The following is a description of a gene set: from publication Amit I, Garber M, Chevrier N, Leite AP, Donner Y, Eisenhaure T, Guttman M, Grenier JK, Li W, Zuk O, Schubert LA, Birditt B, Shay T, Goren A, Zhang X, Smith Z, Deering R, McDonald RC, Cabili M, Bernstein BE, Rinn JL, Meissner A, Root DE, Hacohen N, Regev A (PMID 19729616) studied in species Homo sapiens Human Gene Set: GSE17721_LPS_VS_CPG_8H_BMDC_DN Genes down-regulated in comparison of dendritic cells (DC) stimulated with LPS (TLR4 agonist) at 8 h versus DC cells stimulated with CpG DNA (TLR9 agonist) at 8 h. mouse primary BMDCs were stimulated with tlr ligands and gene expression changes were profiled on Affymetrix arrays, and this is the list of marker genes: CETN3, STT3A, SLC35A1, GSDME, FKBP1A (FKBP prolyl isomerase 1A), PLA2G6, SS18L2, TMEM186, DCPS, SEPTIN8, NUP54, IMPACT, CPB1, GPS2, BTBD1, CXorf38, SLC35A4, PIWIL1, RASSF8 (Ras association domain family member 8), PRKDC, MINDY1, AKR1E2, TLR2, RPS6KB1, LTA4H (NCBI Gene Id 4048), NCBP1, LYSMD3 (LysM domain containing 3), SLC25A11, PLBD2, IL6ST, CEBPA, HEXIM1, MTG2, GSTM1, NDEL1, MCOLN2, GLRX3, SLC38A5, PLPP1, RGS19, CNIH1, FLI1, PCBP1, TBC1D14, DNAJB8, NFS1, GRK5, MED27, PTPN1, ID3, KCNN4, SEPHS2, TBC1D24, SUPT20H, FCGR2A, CAT, SLC7A6, TEX2, CXCL6, SKP2, NFAM1, MYC, PPARG, OLR1, EIF2B1, NUDCD2, CERS2, YAE1, PXN (NCBI Gene Id 80229), MRPL24, TM9SF3, PIGP, KDELR2, ACP5, SCML2, RPL24, IDH1, RPL31, MAN1A2 (NCBI Gene Id 10905), UHRF1, NOL11, EMG1, SUMO3, GLMN, ECT2, ARHGDIB, KCTD4, RPS2, NDUFAF4, BBLN, TARS1, GALK2, POLR2B, CYB5A, CEP20, FBXO22, HERPUD1, NOP56 (NOP56 ribonucleoprotein), PPCDC, DHRS7B, IL36G, WDR36, MSR1, ACO1, APEX2, OXCT1, PSEN2, MED20, SDHD, ORC2, PDF (NCBI Gene Id 86077), GBE1, BPNT1, NPR1, TBXAS1, RPL7L1, GNPTAB, NPRL2, DMAC2L, GDI2, TFEC, GARS1, SURF2, CDK8, GK, TRMT112, TP53RK, PGM2 (phosphoglucomutase 2), ERN2, KPNA2, TSPAN14, PNO1, ATP6V1A, RIOX2, WDFY3, ISYNA1, HSD17B4, GLRX, FPR1, BST1, TNFRSF11A, WDR20, IARS1, NOP16, TRIM59, TRAPPC2, SDC1, XPO5, GSTM5, DIMT1, MTSS1, FLVCR2, ETFDH, PPT2, ARRB1, HDAC3, RTN3, AEN, KDM5C, CTPS2, MPLKIP, ERMP1, SQOR, INTS6L, MRPL50, ZNF639, STYX, CTNNB1, HPF1, ESRRA, RENBP, TLR1, CDK11B, PHTF2, LIAS, NCAPH2, MYO7A, ZFP91, C1orf131, DNA2 (DNA replication helicase/nuclease 2), KLHL7, RANBP9, FAM50A, SAMM50, DNASE1L1, MCFD2 (NCBI Gene Id 90411), CYSLTR1, YWHAB, TCTA, WBP1, DNAJB4, GTF2H4, LMAN2, MAP3K8, MICU1, TUBB2A, RNF5, PUM3, GFM2, COMMD9